The following is a description of a gene set: Binding to a chromo shadow domain, a protein domain that is distantly related, and found in association with, the chromo domain. studied in species Homo sapiens Human Gene Set: GOMF_CHROMO_SHADOW_DOMAIN_BINDING, and this is the list of marker genes: SP100, ATRX, LBR, NIPBL, TRIM28, CHAF1A